The following is a description of a gene set: from publication Hoshida Y, Villanueva A, Kobayashi M, Peix J, Chiang DY, Camargo A, Gupta S, Moore J, Wrobel MJ, Lerner J, Reich M, Chan JA, Glickman JN, Ikeda K, Hashimoto M, Watanabe G, Daidone MG, Roayaie S, Schwartz M, Thung S, Salvesen HB, Gabriel S, Mazzaferro V, Bruix J, Friedman SL, Kumada H, Llovet JM, Golub TR (PMID 18923165) Human Gene Set: HOSHIDA_LIVER_CANCER_SURVIVAL_DN species: Homo sapiens BACKGROUND: It is a challenge to identify patients who, after undergoing potentially curative treatment for hepatocellular carcinoma, are at greatest risk for recurrence. Such high-risk patients could receive novel interventional measures. An obstacle to the development of genome-based predictors of outcome in patients with hepatocellular carcinoma has been the lack of a means to carry out genomewide expression profiling of fixed, as opposed to frozen, tissue. METHODS: We aimed to demonstrate the feasibility of gene-expression profiling of more than 6000 human genes in formalin-fixed, paraffin-embedded tissues. We applied the method to tissues from 307 patients with hepatocellular carcinoma, from four series of patients, to discover and validate a gene-expression signature associated with survival. RESULTS: The expression-profiling method for formalin-fixed, paraffin-embedded tissue was highly effective: samples from 90% of the patients yielded data of high quality, including samples that had been archived for more than 24 years. Gene-expression profiles of tumor tissue failed to yield a significant association with survival. In contrast, profiles of the surrounding nontumoral liver tissue were highly correlated with survival in a training set of tissue samples from 82 Japanese patients, and the signature was validated in tissues from an independent group of 225 patients from the United States and Europe (P=0.04). CONCLUSIONS: We have demonstrated the feasibility of genomewide expression profiling of formalin-fixed, paraffin-embedded tissues and have shown that a reproducible gene-expression signature correlated with survival is present in liver tissue adjacent to the tumor in patients with hepatocellular carcinoma. Survival signature genes defined in adjacent liver tissue: genes correlated with good survival of hepatocellular carcinoma (HCC) patients., and this is the list of marker genes: RAD52, PLCB3, BAIAP2, PTPN2, POLRMT, DST, TXN2, PIGK, ITPRID2, ALAS1, C9, GJB1, ACSM3, XPA, RLF, EMD, ART1, SCG5, TIMM8A, ADRA2B, ZNF185, ADH6, INSM1, AARS1, MZB1, RRM1, C4BPB, AOX1, PPP1R1A, PROS1, RPS6KA5, GRM5, KCNJ3, AKR1A1, PKLR (pyruvate kinase L/R), GCKR, GGCX, IGF1, SC5D, CYP2B6, ATP2C1, USP14, ATP6AP2, PLAAT3, MSH6, HABP2, TTR, DLGAP4 (NCBI Gene Id 22839), ACOT2, TMEM97, PLG, F9, GRK4, TRAF6, C8B, PCYT2, NAAA (N-acylethanolamine acid amidase), HSPE1, SUCLG1, HMGCL, SDHC, ADH5, PCK1, AR, ALDH9A1, NARS2, NENF, SLC37A4, DCAF11, GSTM1, TM7SF2, LIPC, MPC2, DAD1, CREB1, AKR1D1, CALCR, PFKFB1 (NCBI Gene Id 5207), HAAO, NIBAN1, SRSF2, VPS41 (NCBI Gene Id 27072), GCGR, CTBS, ERCC5, HMGCR, RFC2, CPOX, ZER1, CYB5A, DOCK4, SNX10, TDO2, SELENBP1, PSMB3, CPN1, PMM1, PON3, PLCG2, ARF4, ANKRD46, TAF1C, SREBF2, C5, IMPA1, ATP5F1D, EIF2B1, ZBTB17, CUX2 (cut like homeobox 2), GHR, CCT8, PTPN18, SLC4A4